The following is a description of a gene set: studied in species Homo sapiens Combining with the Fc region of an immunoglobulin protein and transmitting the signal from one side of the membrane to the other to initiate a change in cell activity. Human Gene Set: GOMF_IMMUNOGLOBULIN_RECEPTOR_ACTIVITY, and this is the list of marker genes: FCGR2B, FCGR1BP, FCGR2C, CD200R1 (NCBI Gene Id 131450), PIGR, FCAR, FCGR3B, FCGR1A, FCER1A, FCER2, FCGR3A, FCER1G, FCMR (Fc mu receptor), FCGR2A